The following is a description of a gene set: Partitioning of the blastoderm embryo into trunk segmental units. In Drosophila, the trunk segments include thoracic segments and abdominal segments A1 to A8. studied in species Mus musculus Mouse Gene Set: GOBP_TRUNK_SEGMENTATION, and this is the list of marker genes: Nrp1, Sema3f, Nrp2, Lama5, Shh, Sema3a